The following is a description of a gene set: Mouse Gene Set: HOUNKPE_HOUSEKEEPING_GENES Housekeeping (HK) genes are constitutively expressed genes studied in species Mus musculus List of 1130 human and mouse housekeeping genes. This list shows the overlap of human genes stably expressed across 52 tissues and cells types and mouse genes with at least one of their transcripts expressed across 14 tissues and cells types. from publication Hounkpe BW, Chenou F, de Lima F, De Paula EV (PMID 32663312), and this is the list of marker genes: Tbcd, Arf1, Rps19bp1 (NCBI Gene Id 66538), Nt5c2, Csnk2b, Snrnp35, Lrrc59, Napa, H2az2 (NCBI Gene Id 77605), Isca2, Rala, Ythdf1, Wac, Zfp706, Chmp4b, Nedd8, Ncoa5, Tex261, Derl1, Prep, Tmem50a, Rab2a, Atpaf1, Dync1li1, Tmem258, Zfp593, Ccdc97, Nelfb, Bloc1s2, Nmd3, Clptm1l, Thap11, Mgrn1, Srsf3, Vdac1, Gnb1, Lamtor1, Pdcd6, Nudt16l1, Lrrc41, Rpl4, Gpi1, Usp14 (ubiquitin specific peptidase 14), Mecp2, Tsr1, Mrps16, Nifk, Drg1, Srsf4, Nmt1, Amfr, Pcgf3, Dnajb11, Hnrnpdl, Hax1, Slc25a3, Sar1a, Mrpl36, Vcp (valosin containing protein), Cd2bp2, Hdlbp, Tmem230, Ssr2, Sec62, Rad23a, Mrpl22, Os9, Ctnnb1, Vezf1, Tram1, Cops4, Nufip2, Cul3, Gga2, G3bp1, Ssna1, Psmb1, Mtpn, Cdc37l1, Anp32a, U2af2, Gtpbp1, Hsf1, Josd1, Mrps25, Snx27, Tollip, Golga3, Pcyox1, Cdc42se1, Paf1, Strn4, Cops5, Mrps14, Rab1b, Mtor, Raly, Ilf3, Ncl, Gfus (GDP-L-fucose synthase), Cbx1, Pelp1, Copg1, Kpna3 (NCBI Gene Id 16648), Serbp1, Ccdc124, Kdm4b, Utp18, Bcap31, Prkar2a, Rab11a, Wbp4, Clns1a, Stub1, Parp1, Sptssa, Copa, Sf3b1, Acbd3, Ngrn, Rhbdd2, Smyd5 (SET and MYND domain containing 5), Sumo1, Med19, Maea, Magoh, Tor1a, Gpkow, Stx4a, Ilf2, Psmc1, Bod1, Psmd8, Sugt1, Dnajc5, Brd4, Comt, Aip, Dnttip1, U2af1, Ube2q1, Rbm25, Cmpk1, Pop7, Cggbp1, Marchf5, Mlec, Adh5, Cipc, Stim1, Spryd3, Btbd2, Fibp, Armc1 (NCBI Gene Id 99874), Pdzd11, Gosr2, Atf6, Jtb, Med4, Erlec1, Luc7l3, Mycbp2, Dnajc13, Fbl, Ring1, Gsk3a, Nus1, Zc3h11a, Pmpca, Cyb5b, Ddx27, Scyl2, Sgta, Dcaf12 (DDB1 and CUL4 associated factor 12), Larp4b, Pithd1, Araf, Trappc3, Get3, Get4, Usp22, Smpd1, Zc3h15, Cct2, Hsd17b12, Cnppd1, Pgrmc2, Pcyt1a, Tardbp, Tbcb (NCBI Gene Id 66411), Vps26b, Rbm4, Timm22, Rangap1, Akirin2, Slc25a5, Psmg2, Fam50a, Oxsr1, Bet1l, Hnrnpd, Tmx4, Sec61b, Nup153, Mapre1, Srsf10, Bltp2, Mfsd14a, Fam168a, Wipi2, Atg3, Gpbp1, Usp39, Zmpste24, Sh2b1, Ankrd40, Fam98a, Eif3e, Txnl1, Erp44, Naca, Cct4, Zfp865, Spag9, BC005624, Sap18, Dnajc11, Psma5, Tax1bp1 (NCBI Gene Id 73506), Kbtbd2, Srp9, Smarcc1, Cdc5l, Cby1, Actr1a, Tubg1, Eif1ax, Tab1, Ino80, Rab7 (RAB7, member RAS oncogene family), Mfn2, Atp6v0e, Exosc4, Cul1, Spg7, Eefsec, Max, Eif2s1, Smap1, Cactin, Ik, Gid8, Mphosph10, Mrto4, Tbc1d20, Ndst1, Ubqln1, Srrm1, Psmd11, Ppp6r1, Ubxn1, Emc2, Etf1, Uba2, Gtf3c6, Smdt1, Tmem147, Rgp1, Nudc, Tbk1, Hnrnpul1, Taf10, Eral1, Mrpl41, Hipk1, Atg101, Ywhaq, Dnajc4, Ppp2r5e, Gorasp2, Rars2, Trip4, Usp4, Ap3m1, Ebag9, Pcmtd2, Snx19, Ppp1r37, Lamp2, Ddx1, Kpna4, Fem1b, Aamp, Rbx1, Chmp6, Zfpl1, Elk1, Tmem42, Eif4a1 (eukaryotic translation initiation factor 4A1), Rrp7a, Dcaf15, Chmp2a (NCBI Gene Id 68953), Hnrnpu, Eif4h, Mrpl9, Ell, Nudt21, Ywhab, Iscu, Ssbp1, Spag7, Smarcb1, Trim28, Syncrip, Leng8, Igbp1, Khsrp, Pwp1, Gatad2b, Elavl1, Sf3b5, Ap3s2, Ssrp1, Ubap2l, Stt3b, Lman2, Rbck1, Rnf167, Bckdk, Fkbp8, Mrpl38, Rab3gap1, Kpna1, Ostc, Map2k1, Rnf20, Commd7, Hnrnpab, B4galt7, Psmd6, Btf3l4, Rere (NCBI Gene Id 68703), Ergic3, Nap1l1, Fam32a (family with sequence similarity 32, member A), Bsdc1, Cops6, Prkcsh, Ipo5, Acbd6, Ranbp9, Rtf1, Mrpl24, Tmem203, Pacs1, Arhgap1 (NCBI Gene Id 96949), Zc3h3, Ankrd10, Pbdc1 (polysaccharide biosynthesis domain containing 1), Icmt, Rab35, Pgam5, Lsm1, Anapc2, Srm, Kifbp, Hsp90b1, Ftsj3, Arih2, Yars1, Bap1, Cmtr1, Lsm14a, Slc35a4, Ctnnbl1, Sp2, Pum2, Ensa, Pfdn2, Mrps30, Srprb, Zbtb17, Lrpap1 (NCBI Gene Id 97224), Pcbp2, Pno1, R3hcc1, Crk, Ndufb8, Rnf216, Nob1, Zfp91, Dusp11, Stx5a, Atp6ap2, Nap1l4, Prdx5, Coa3, Ssu72, Rpn1, Yipf3, Lman1, Tmx3, Pds5a, Dhps, Prdm4, Eapp, Thrap3, Fiz1, Rpa2, Crkl, Guk1, Mtdh, Atp5pf, Fbxo28, Vti1b, Emc3, Sf3a3, Zmynd19, Slc25a28, Yme1l1, Mrpl17, Psmb2, Ube3c, Ccdc47, Hmgxb3, Sav1, Mrps28, Lsm14b, Sod1 (NCBI Gene Id 319325), Hp1bp3, Ahsa1, Gtf3a, Sharpin, St13, Morc2a, Gtf2f1, Crebbp (CREB binding protein), Ak2, Rnps1, Brk1, Pdia6, Tnks, Cdc23, Mettl9, Kcmf1, Eif3i, Aggf1, Cfl1, Ints10, Mrps2 (NCBI Gene Id 76345), Spg11, Prpf18, Ipo8, Mrps17, Ak3, Psmd3, Ythdc1, Ralbp1, Srebf2, Ssr3, Denr, Pabir1, Gtf3c3, Mrpl43 (NCBI Gene Id 94067), Numa1, Mccc2, Tmem165, Hcfc1, Nsmce4a, 1600012H06Rik, Rbm14, Rer1, Eif2b1, Htt, Casc3 (NCBI Gene Id 192160), Htatsf1, Dap3, Kdelr1, Tomm70a, Snrpd3, Gbf1, Rpl35a, Dcaf5, Hat1, Pip5k1c, Sars1, Txndc12, Ppp5c, Vps16, Rab5a, Psmg3 (NCBI Gene Id 78793), Eif2d, Adipor2, Phf12, Csnk1d, Pnrc2, Timm17b, Tnks2, Aars1, Ier3ip1, Psmc5, Tpp2, Bud31, Srsf1, Mrps5, Snrpa, Psma6, Psme3, Cebpz, Aldh9a1, Purb (purine rich element binding protein B), Ngdn, Rabggtb, Ltv1, Tusc2, Stk38, Yy1, Mtch1, Qrich1, Fam20b, Lsm4, Rnf181, Gnpat, Rbmx2 (RNA binding motif protein, X-linked 2), Pa2g4, Tada2b, Osbp, Abcf2, Srsf6 (serine and arginine-rich splicing factor 6), Lrpprc, Rab11b, Snx3, Park7, Morf4l2, Emc7, Flcn, Kat8, Gle1, Tsr3, Rc3h2, Aarsd1 (NCBI Gene Id 69684), Psmb6, Cebpzos, Hint1, Nsmce1, Stk11, Ppp1cc, Dnajc9, Dctpp1, Cab39, Btf3, Usp48, Nucks1, Pafah1b1, Rab9, Rpl15, Bag1, Dnajc3, Rsl24d1, Gtf2f2, Lyset, Ddx17, Exoc2, Mrps9, Ilkap, Api5, Ddb1, Nsa2, Cog3, Ddx18, Pcmt1 (NCBI Gene Id 97645), Terf2ip, Kdm2a, Edc3, Rbm17, Ptrh2, 1700123O20Rik, Arl8b, Ppp2ca, Ubl4a, Aida, Mepce, Akt1, Alkbh5, 4933434E20Rik, Zdhhc6, Mbd1, Fam168b, Mtfr1l, Stx8, Sf1, Srsf11, Psme3ip1, Slc30a5, Wasl, Plaa, Dimt1, Chchd1, Tor1b, Prpsap1, Mydgf, Nup133, Baz1b, Csnk1g2, Wdr46, Pofut1, Ankfy1, Arcn1, Vps37c, Psmd7, Zfp330, Pcsk7, Copz1, Rad21, Klhdc10, Aar2, Gatad1, Cnot11, Srp14, Rbm42, Sdf4, Ap1g1, Borcs7, Nrbp1, Ranbp10, Dnajc7, Zfp146, Rab6a, Hnrnpa2b1, Tada3, Sf3b6, Clpp, Egln2, Snrpb, Dad1, Dnaja2, Dhx40, Dnajc1, Cox15, Coq5, Sbds, Rhot2, Adrm1, Dpy30, Pin1, Rac1 (Rac family small GTPase 1), Tmem259, Rab14, Ubac1, Snx1, Rad23b, Aph1a, Arfgap2, Phrf1, Slc4a1ap, Rheb, Erp29, Wdr83os, Golga4, Mrpl18, Nop14, Ubr4, Sec13, Snrnp70, Kctd20, Dennd6a, Mmadhc (methylmalonic aciduria (cobalamin deficiency) cblD type, with homocystinuria), Mau2, Cmas, Gsto1 (glutathione S-transferase omega 1), Tmed4, Ube2f, Arf4 (ADP-ribosylation factor 4), Emd, Ebna1bp2, Ccdc50, Son, Snap29, Npepps, Tmem30a, Ufm1, Bad, Dars1, Coa6, Psmd12, Stip1, Gtf2e2, Trpc4ap, Eif3b, Csnk2a1, Pwp2, Mkrn2, Skp1, Dnaja3, Rtcb, Arfgap3, Prkar1a, Eif3d, Tbca, Vps25, Sp1, Tomm22, H3f3b, Ctdnep1, Ubqln4, Med9 (NCBI Gene Id 192191), Med25, Vps26a, Erh, Armcx3, Cdc34, Man1a2, Hnrnpul2, Rpl7l1, Zranb1 (NCBI Gene Id 77556), Zfp777, Dhx15, Faf2, Frg1, Ppt1, Tmco1, Psmd5, Prpf19, BC004004, Ppib, Cnbp, AU040320, Arpp19, Cdc16, Mrpl57, Msl2, Tomm20, Tmed1, Eri3, Pdpk1, Kdelr2, Ankrd52, A430005L14Rik, Apeh, Trmt112, Rpl22, 1810009A15Rik (NCBI Gene Id 66276), Taok2, Cdk4, Fhip2a, Iqsec1, Mrpl37, Mrpl14, Kpna6, Kctd5, Rnf139, Eif4a3, Zfyve21, Srsf9, Pdap1, Arl14ep, Slc35e1, Ankle2, Polr3c, Zyg11b, Hsp90ab1, Hapstr1, Uba1, Fbxl3, Hspe1, Fbxo42, Larp1, Ranbp2, Chtop, Zdhhc7, Skic3, Zmiz1, Supt6, Ccz1, Prcc, Tmbim6, Zranb2, Cdc37, Psmd4, Med10, Cox17, Ccdc22, Tcp1 (NCBI Gene Id 435546), Cdc123, Nfatc2ip, Coasy, Arnt, Epn1 (epsin 1), Ppp1r15b, Psma7, Polr2k, Vps52, Stk24, Lamtor5, Tsn, Tmem127, Rpn2, Lemd2, Psmd1, Slc35a1, Slirp, Ube2g1, Mrpl49, Gnptg, Ppp6r2, Cuedc2, Ints12, Dhx38, Kras, Vps36, Pigh, Arfgef2, Ccnk, Eif3g, Bfar (NCBI Gene Id 67118), Hnrnpm, Acad9, Senp5 (SUMO/sentrin specific peptidase 5), Ndufaf2, Eif3k, Fis1, Dctn4, Nfx1, Rrn3, Ost4, Hgs, Fubp3, Kxd1, Cuta, Ubp1, Cdc42, Iws1, Polr2c, Zmat2, Pdcd7, Ruvbl1, Senp2, Mrpl28, Ppid, Txn2 (NCBI Gene Id 80503), Pabpn1, Gtf2b, Mief1, Jagn1, Ergic1, Syf2, G6pc3, Pfdn1, Tm9sf3, Chmp3, Psmc3, Paip1, Bnip3l, Polr2j, Psma2, Sart3, Ldb1, Ufc1, Ppp2cb, Ppp2r5a, Stat3, Jak1, Smad2, Anp32b, Itch, Sephs1, Fbxw5, Atf6b, Tbl1xr1, Usb1, Ccar2, Rnf113a2, Snd1, Sart1, Ipo9, Preb, Smim11, Ap2m1, Lars1, Eif5a, Phf5a, Fzr1, Ddx23, Gnl2, Btbd1, Ddx51, Nploc4, Ywhae, Dnaja1, Lonp2 (NCBI Gene Id 66887, lon peptidase 2, peroxisomal), Wdr82, Med13, Pacsin2, Cul4b, Snapin, Pold2, Sf3b2, Dctn2, Banf1, Gpn3, Nat10, Clptm1, Prps1l3, Ranbp1, Ube2z, Tmed10, Tspyl1, Urod, Prkra, Gspt1, Dhx29, Higd1a (HIG1 domain family, member 1A), Actr1b, Ncbp2, Abce1, Elof1, Tmem60, Med21, Tmem101, Cand1, Pdia3, Wdr55, Psmd14, Sub1, Mrpl39, Copb2, Deaf1, Nudt9, Otud4, Mlf2, Gabarapl2, G3bp2, Sppl3, Tmem219, Sec31a, Dctn3, Nosip, Patl1, Gpx4, Dnlz, Psmb4, Ppp6c, Pafah1b2, Appl1, Snx12, Eif5b, Yif1a, Snf8, Parn, Ugp2, Mrpl51, Cdkn1b, Csnk2a2, Aasdhppt, Fxr2, Prkaa1, Serp1, Arl1, Fbxw4, Bmi1, Puf60, Calr, Ubfd1, Nars1 (asparaginyl-tRNA synthetase 1), Ube2r2, Cfdp1, Mcts1, Rnf168, Txndc9, E2f4, Strap, Ube2d2a, Sdhaf2, Emc8, Pcif1, Slc25a11, Golph3, Sarnp, Ddx47, Tut1, Kdm1a, Rrp36, Ufl1, Maz, Chmp2b, Psmb7, Ube2k, Eif1b, Wrnip1, Tmem245, Mrps10, Pptc7, Nxf1, Pten, Eef1d, Coa5, Ube2j1, Rrp9, Ttc1, Eif4g2, Eif2s2, Pole3, Surf4, Asnsd1, Med28, Timm17a, Hdhd2, Anks1, Tmem248, Prpf38a, Dnajb6, Bag6, Msl1, Cdc26, Mea1, Smu1, Mcrs1, Sec24b, Rsrc2, Ccni, Eif4b, Bccip, Wdr45b, Hspa4, Gpn2, Tmed9, Chp1, Pcbp1, Smc1a, Ddx19a, Mapk1ip1l, Arl6ip1, Napg, Slu7, Emc6, Rpa1, Mrpl44, Ppp1r8, Fcf1, Vps29, Map2k2, E4f1, Ncbp1, Csnk1a1, Slc30a9, Dynlrb1, Crtc3, Lsm12, Nol7, Rmnd5a, Polr1d, Dnajc8, Arpc2, Srsf2, Tmem256, Rraga, Mcmbp, Whamm, Brms1, Ptpn11, Ppp2r5c, Slc39a6, Emc4, Rabl6, Sf3b4, Ctbp1, Tpi1, Trip12, Nfyb, Eif2ak1, Psmd10, Utp3, Sfpq, Ubl5, Ubl7, Hsbp1, Ube2i, Brd3 (NCBI Gene Id 99302), Thoc7, Rbm8a, Actr2, Phaf1, Gdi2, Smim12, Keap1, Akirin1, Lonp1, Ogt, Smarca5, Ppp2r1a, Mbd2, Eif3m, Herpud2, Xpot, Tmem183a, Lcmt1 (leucine carboxyl methyltransferase 1), Tcf25, Nop9, Otub1 (OTU domain, ubiquitin aldehyde binding 1), Sf3a2, Pbx2, Setd5, Agap3, Cog7, Ppp1r11, Hnrnpa1, Bub3, Sltm, Stau1, Lmf2, Zc3h18, Mapk8ip3, Mapk1, Khdrbs1, Morf4l1, Bzw1, Vps51, Asxl1, Calm1, Cope, Ykt6, Scaf1, Sh3gl1, P4hb, Eif3a, Scyl1, Leng1, Pmpcb, Kars1